The following is a description of a gene set: A protein complex which is capable of endodeoxyribonuclease activity. species: Mus musculus Mouse Gene Set: GOCC_ENDODEOXYRIBONUCLEASE_COMPLEX, and this is the list of marker genes: Slx4, Eme2, Rag1, Rad51c, Mus81, Eme1